Given this list of marker genes APOBEC3A, APOBEC4, APOBEC3B, APOBEC3H, A1CF, ADARB1, ADAR, APOBEC1, APOBEC2, APOBEC3C, here is a description of the gene set: mRNA Editing Human Gene Set: REACTOME_MRNA_EDITING studied in species Homo sapiens